The following is a description of a gene set: A bending or abnormal curvature affecting a long bone of the leg. Human Gene Set: HP_BOWING_OF_THE_LEGS studied in species Homo sapiens Bowing of the legs, and this is the list of marker genes: TMEM270, EXT2, IFIH1 (NCBI Gene Id 64135), PRKAR1A, CCDC47, FN1, SLC34A1, ORC1, EVC2, TBC1D7, PEPD, CLCN5, RUNX2, NOTCH2, SF3B2, FGFR2, ACTA1, SLCO2A1, CBS, MAPK8IP3, ORC6, CTCF, PUS3, HEATR3, FLNA, RECQL4, MTX2, VPS13B, TCTN3, FIBP (NCBI Gene Id 9158), TONSL, MEGF8, COL11A1, CTNS, NF1, DYNC2I1, KAT6A, SATB2, LIMK1, COL2A1, TRPV4, FBN1, TMEM38B (transmembrane protein 38B), ATP7A, NEPRO, MBTPS2, SMOC1 (NCBI Gene Id 64093), PRKACA (protein kinase cAMP-activated catalytic subunit alpha), IDH1, RBM8A, CSGALNACT1 (NCBI Gene Id 55790), CDC45, TRIP11, SHOX, PCYT1A, TUBB3, GLI1, SOX9, LBR, NAA60, CLDN16, MEG3, PLAAT3, CFL2, NPAP1, GAN, SKI, STX1A, SLC26A2, SLC10A7, PRKG2, EIF4H, PTH1R, SCARF2, TENT5A, ELN, SLC34A3, PLOD2, TNFSF11, ARSB, HS6ST1, CYP19A1, DDRGK1, UFSP2, SPTBN1, HSPG2, MATN3, TNFRSF11B, SETBP1, BCOR, ENPP1, BMP1, NSD1, LIFR, HBB, IARS2, FKBP6, LTBP1, IDH2, CLCN7, NEK8, ZBTB20, TTI1, CAMK2A, DDR2, RAB23, HERC2, TPM2, TBL2, MKRN3, CCN6, GLB1, CLTCL1, GUSB, MAGEL2, ZNF699 (zinc finger protein 699), P4HTM, RPGRIP1L (RPGRIP1 like), DLK1 (NCBI Gene Id 8788), P3H1, COL11A2, COL10A1, COL9A1, BRF1, MTAP, CYP3A4, NDUFAF6, COG5 (component of oligomeric golgi complex 5), CRTAP, PDE4D (NCBI Gene Id 654081), TFE3, TGDS, COL1A2, SERPINF1, LMOD3, RAD21, VDR, RSPRY1, ARSK, ACP5, IHH, XYLT1 (NCBI Gene Id 64131), FGF23 (NCBI Gene Id 8074), CCN2, MPZ, TNFRSF11A, CILK1, PHLDB1, CYP27B1, EVC, ATRX, POLRMT, ALPL, EIF2AK3, EHHADH, IDUA (alpha-L-iduronidase), NEK9, B3GAT3, IPO8, SERPINH1 (serpin family H member 1), PAPSS2 (3'-phosphoadenosine 5'-phosphosulfate synthase 2), TRPV6, NKX3-2, ADNP, DYNC2H1, LAMA5, SPART, CBFB, ANAPC1, POR, DYM, EFL1, LRP5, COL1A1, BMP4, DNAJC30, PMP22, KRAS, COMP, TRPS1, FGFR3, RFC2, GORAB, SNORD115-1, KLHL41, ZEB2, ARCN1, DMP1, MCTP2, CENPT, IFT57 (NCBI Gene Id 55081), PDGFRB, METTL27, BAZ1B, GALNS, OCRL, GTF2I, BUD23, NCF1, GTF2IRD2, MAN2B1, CTC1, PCNT, CPLANE1, COL9A2, ZPR1, IFT172, FLNB, DYNC2LI1, RPL13, BRAF, RNU4ATAC, CHST3, MMP9, MMP13, SFRP4, HPGD, GNPTG, UGP2, CLIP2, COL9A3 (NCBI Gene Id 1299), CYP2R1, POLR1A, NEB, B3GALT6, MAP2K2, SGMS2, BHLHA9, KDELR2, LONP1, RAB33B, WNT7A, BPNT2, RMRP, GTF2IRD1, SP7, GDF5, TGFB1 (NCBI Gene Id 7040), EXT1, ACAN, PWAR1, RTL1, MAP2K1, H3-3B, CANT1, KIF7, PHEX, PWRN1, KIF22, WDR62, SNORD116-1, BGN, PRKACB, POLR3A, VPS37D, HS2ST1